The following is a description of a gene set: Mouse Gene Set: MIR_12178_5P Genes predicted to be targets of miRBase v22 microRNA mmu_miR_12178_5p in miRDB v6.0 with MirTarget v4 prediction scores > 80 (high confidence targets). studied in species Mus musculus from publication Chen Y, Wang X (PMID 31504780), and this is the list of marker genes: Btnl2, Dsp, Prrg1, Nptx1, Henmt1, Fgf13, Mccc2, Gal3st2c, Zfp983, Pgr, AI593442, Ugt2b34, Kdm2a, Eif4g2, Alg6, Tsc22d1, Rap1gds1, Mecr, Nlrp1a, Tlcd3b, Mfap5, Slc4a8, Foxj2, Sbspon, Swsap1, Wbp4, Msi2, P4ha3, 1700029F12Rik, Col6a4, Klf16, Cadm2